The following is a description of a gene set: Mouse Gene Set: GOBP_POSITIVE_REGULATION_OF_GLIOGENESIS species: Mus musculus Any process that activates or increases the frequency, rate or extent of gliogenesis, the formation of mature glia., and this is the list of marker genes: Ntn1, Plag1, Prkci, Zfp488, Prkch, Prmt5, Egr2, Mir23a, Gjc2, Slc7a5, Dicer1, Nog, Igf1, Clcf1, Mtor, Enpp2, Rnf112, Il34, Arrb2, Zfp365, Gfap, Etv5, Myc, Olig2, Trf, Rela, Ptpra, Mecp2, Serpine2, Notch1, Lif, Csf1r, Ptn, Il33, Tlr2, Ppp1cc, Trp73, Mag, Actr3, Tgfb1, Rheb, Atxn1, Prpf19, Aspa, Cysltr1, Nkx6-2, Myrf, Il6, Rtn4, Nkx2-2os, E2f1, Tenm4, Shh, Id2, Nrg1 (NCBI Gene Id 320603), Hes1, Vim, Flt1, Mir219a-2, Cxcr4, Qki, Bag1, Bin1, Sox8, Ntf3, Lta, Tnf, Tspo (translocator protein), Hdac2, Mdk, Tnfrsf1b, Egfr, Mir219a-1, Il6st, Lrp2, Lyn (NCBI Gene Id 99963), Bmp2, Ptk2, Hdac1, Kras, Il1b, Spint1, Ptprz1, Gsx2, Pparg, Dag1, Synj1, Myb, Nkx2-2, Nkx6-1, Clcn2, Ufl1, Vegfc, Sox10